Given this list of marker genes NRF1, BIRC3, TRMT2B, SLC25A15, PTK2B, ROBO1, CNOT4, STK38, GLDC, KIAA0040, ARHGAP25, SMPD3, MAML1, UCN (NCBI Gene Id 7349), ZNF667, KCNH2, DDX24, DYRK1A, IGHV5-78, SARS2, DEF6, IGHM, SPATS2, E2F5, TNK2, PRKDC (protein kinase, DNA-activated, catalytic subunit), BAZ1B, PMS2P3, EPHA4, MAP3K1, UBR4, ZZEF1, NASP, HLA-DPB1, SATB1, TERF2IP, TM6SF2, SLC35E2B, MRFAP1L1, PPA1, ALDOB, PATJ, MARCHF3, MEIS1, DENND1C, KDM6A, PRKD2, TSPYL1, GPR31, LRIG2, RAF1, CDK5RAP3, GPATCH8, MRPS27, UBE2N, HERC3, RALGPS2, IFITM1 (interferon induced transmembrane protein 1), NUP133, PMS2P2, CORIN, ZNF510, ADAM29, NFX1, IGFLR1, GJD2, LRRC14, MZF1, FARS2, EXTL1, ZNF574, TMEM131, RUFY1, CARS1, LAX1, ENTR1, SET, BACE2, SMIM27, ITGA10, E4F1, RERE (NCBI Gene Id 9642), STOML1, CHKB, SLC25A17, DAZAP2, EHD3, TMEM80, RNFT2, TESK2, ZDHHC4, RPSA, SCN3A, NPHP1, R3HCC1, TEX10, EZR, SLC41A3, ZNF473, CD72, PIP5K1B, FAM30A, NDST3, EEF1D, TRAF3IP3, S100A7, NAP1L4, ARHGEF9, PFAS, CRB1, BCOR, ENO3, PNO1 (partner of NOB1 homolog), SYNE1, HNRNPA0, RPL39, OSBPL3, SYNGR3, KDM7A, OAS2, PMS2P1, HLA-DOB, ENSG00000291006, PSME1, FAM234B, CLASP1, RPS29, ICAM3, CTBP1, COQ6, MED16, PDP1, COL18A1, IGHA1, NAA40, RGS7, HAUS7, RPL4, PIAS3, RPS12, ZC4H2, GNB5, MAEA, SRSF8, CSGALNACT1, EGR3 (early growth response 3), FBXL14, NLRP1, CAPN10, TRIM22, POLG, PTPRK, FAM193B, ZNF250, PHF1, MPHOSPH8, FCMR, LAS1L, IGKC, IRF4, ISG20L2, JADE2, HHEX, SEPTIN6, CASP4, CREBBP, SMARCC1, IL15RA, ZBP1, MARCHF8, PPM1E, SDR39U1, PRPSAP2, PSD4, RNPS1, ZDHHC8BP, GIT2, HCP5, TRAPPC2, HSF2, TBKBP1, TBC1D5, GTF2A1, IGLL1, RPL19, MAT2A, PCIF1, KRT18, TP63, TMSB15B, ITM2C, CLDN17, AP1G2, UBA7, ZCWPW1, SYNE3, RPL12, here is a description of the gene set: from publication Jeffrey KL, Brummer T, Rolph MS, Liu SM, Callejas NA, Grumont RJ, Gillieron C, Mackay F, Grey S, Camps M, Rommel C, Gerondakis SD, Mackay CR (PMID 16474395) Genes down-regulated in comparison of macrophages versus B cells. In the present study we used Affymetrix oligonucleotide microarrays to produce gene transcription profiles for the major leukocyte types in humans. This comprehensive dataset enabled us to not only establish which genes were expressed in each leukocyte type, but also which genes were expressed in each subset after activation. The used of a comprehensive dataset of gene profiles from all the major human leukocyte subsets enabled a novel and powerful means for identification of genes associated with single leukocyte subsets, or different immune paradigms. Human Gene Set: GSE3982_MAC_VS_BCELL_DN species: Homo sapiens